Given this list of marker genes ACER2, ACER1, ASAH2B, NAAA, ASAH2, ACER3, ASAH1 (NCBI Gene Id 79795), here is a description of the gene set: species: Homo sapiens Catalysis of the reaction: an N-acylsphing-4-enine + H2O = a fatty acid + sphing-4-enine. Human Gene Set: GOMF_N_ACYLSPHINGOSINE_AMIDOHYDROLASE_ACTIVITY